Given this list of marker genes Ajuba, Usp19, Chchd2, Vhl, Ep300, Drd1, Kdm6a, Eno1b, Dnmt3a, Tmbim6 (transmembrane BAX inhibitor motif containing 6), Pik3cb, Hyou1, Daxx, Eno1, Nol3, Chchd2-ps, Map2k1, Stat3, Epha4, Pink1, Rock2, Nfe2l2, Ddah1, Drd2, Commd1, Kcnk2, Ogt, here is a description of the gene set: studied in species Mus musculus Mouse Gene Set: GOBP_REGULATION_OF_CELLULAR_RESPONSE_TO_HYPOXIA Any process that modulates the frequency, rate or extent of cellular response to hypoxia.